The following is a description of a gene set: Mouse Gene Set: GOMF_MISMATCH_REPAIR_COMPLEX_BINDING studied in species Mus musculus Binding to a mismatch repair complex., and this is the list of marker genes: Trex1, Mcm8 (minichromosome maintenance 8 homologous recombination repair factor), Pcna, Pms2, Mutyh, Msh6, Mlh1, Msh2, Atr, Wrn, Mcm9